The following is a description of a gene set: species: Mus musculus Human Gene Set: YAO_TEMPORAL_RESPONSE_TO_PROGESTERONE_CLUSTER_4 from publication Yao MW, Lim H, Schust DJ, Choe SE, Farago A, Ding Y, Michaud S, Church GM, Maas RL (PMID 12554760) Human infertility and recurrent pregnancy loss caused by implantation defects are poorly understood. Hoxa-10-deficient female mice have severe infertility and recurrent pregnancy loss due to defective uterine implantation. Gene expression profiling experiments reveal that Hoxa-10 is an important regulator of two critical events in implantation: stromal cell proliferation and local immunosuppression. At the time of implantation, Hoxa-10 mediates the progesterone-stimulated proliferation of uterine stromal cells. Hoxa-10 mutants express a stromal cell proliferation defect that is accompanied by quantitative or spatial alterations in the expression of two cyclin-dependent kinase inhibitor genes, p57 and p15. Hoxa-10 deficiency also leads to a severe local immunological disturbance, characterized by a polyclonal proliferation of T cells, that occurs in place of the normal progesterone-mediated immunosuppression in the periimplantation uterus. Genes co-regulated in uterus during a time course response to progesterone: SOM cluster 4., and this is the list of marker genes: DRD4, YBX2, FKBP10 (FKBP prolyl isomerase 10), CCDC90B, GALR2, BARX1, AK4, RGS5, GCAT, IGLV4-69, SYNGR4, ERCC2, MC2R, FDPS, RCC2, LDLR